The following is a description of a gene set: from publication Yevshin I, Sharipov R, Kolmykov S, Kondrakhin Y, Kolpakov F (PMID 30445619) Genes containing one or more binding sites for (TEAD2) in their promoter regions (TSS -1000,+100 bp) as identified by GTRD version 20.06 ChIP-seq harmonization. Human Gene Set: TEAD2_TARGET_GENES species: Homo sapiens, and this is the list of marker genes: ZRANB2-DT, SRP14-DT, TIGAR, PRDM10, SYDE2, PCNX4-DT, CARS2, DCP1B, SHOC2, H2AC6, RHBDD3, OGDH, GDF9, SEC14L1, LSR, TTLL7, PDCD6P1, TIMM22, RN7SL3, HUS1, POLG-DT, SYNJ2BP-COX16, GPAT3, CNBD2, PSMB9, ZNF397, MCM9, ATG12, NCAPD2, SRP14, SKA2, RABGAP1, DDX54, DEPDC4, RITA1, ZNF106, EIF4G2, POC5, UIMC1, SLC38A6, ITGAV, SMIM12, SNX8, TDRKH, LINC01342, PRMT1, SAMD4B, NIPAL3, VAV2, RPS4X, TDRKH-AS1 (NCBI Gene Id 109729141), OXR1-AS1, LATS2, MRPS33, MRPL42P1, TAF11, UQCR10, HOXA-AS3, SRSF7, STAT2, MIP, GPN3, AAAS, SCAF11, CCN1, LDLR, HSP90AB1, MFSD4B (major facilitator superfamily domain containing 4B), PRR5, RPL32, DST, SMARCA2 (NCBI Gene Id 95083), NOL7, TOLLIP-DT, HBP1, KIF3A, ENSG00000250230, ALDH4A1, TRIP6, POLR3B, GOT1-DT (GOT1 divergent transcript), RNU6-1, ATP5MG, PRDX2, WASF2, CFAP119, APOL2, MED19, RPS6KA1, SRSF1, RAB3GAP1, ATF7, MRPS10, ZMAT5, CENPO, LINC00339, SNHG20, LDAH, GCA, VPS33A, CPVL, RHOF, RAB21, PPP4R3B, TUBA1B, GIRGL, RALA, WDR36, TINF2, MIR3646, FAM133B, ATP8A1-DT, EHD1, SHLD3, PARPBP, RSRP1, TMEM183A, ATP1B3, ENSG00000246308, C2CD4A, C1orf105, MYL12A (myosin light chain 12A), CCDC90B, PIGB, ADO, ULK4, ZNF490, NEK4, YARS1, EIF5A, TLR3, DUS4L, POLR2K, RPRD2, GABARAPL1, PPRC1, TMEM68, ZNF691-DT, SNORA3A, PACSIN2, SNHG32, BECN1, MRPL27, METAP2, SUGT1-DT (NCBI Gene Id 116435302), GTF2A1-AS1, PSIP1, DHX30, CSNK1G3, SNX33, ERG28, CALM2, EEF1B2, POLG2, BTD (biotinidase), UFSP2, CRNKL1, FUCA1, CDC25C, CENPK, STRIP2, MRNIP, ATR, CBLL1, ENSG00000227218, ZBTB37, GPALPP1, PPM1D (protein phosphatase, Mg2+/Mn2+ dependent 1D), UTP3, AP3S2, GLRX, DLGAP4-AS1, HNRNPD, SMIM7, YAE1-DT, UBE2D3, COX15, HSD17B11 (NCBI Gene Id 51170), LINC01635, TK2, ASB3, RNF115, TAGAP-AS1, PRDM10-DT, EEF1AKMT3, TRIM23, TP53INP1, ZBTB8OS, LINC00471 (NCBI Gene Id 151477), HSPA5, PNO1, DAZAP2, SUGCT, ASAH1, PPM1L-DT, EIF3M (NCBI Gene Id 63319), CFDP1, LIPE, U2AF2, GPATCH2, SUCLG1, MIR200CHG, BCL7B, TPBG, ANKRD13A, PRMT5-AS1, ZNF691, TATDN3, PKNOX1, KIF18B, MOCS3, S100PBP, JADE2, ALDH1A2, CDON, POMK, CDCA3, FUS, H2AC7, ERCC5, YY1AP1, PPP2R5E, ABCF2, BOLA1, LINC00881, PBX3, ARMC8 (NCBI Gene Id 29067), BMERB1, MRPS24, PAFAH2, UBE4A, SHC1, KRT20, FAM227B, SPRY4, FAM156A, ASF1A, ITGA3, POLR1B, TAFA2, PEX5, ARHGAP26, SEPTIN9, PPA1, GAPDHP25, RPL26, PRR11, THADA (NCBI Gene Id 63892), KMT5A, H2BC12, FAF1, HRCT1, TUBA1B-AS1, RNF43, TSFM, MAPK14, INTS2, PKIB, FBXO33, CDCA7L, DNAAF8, TRIM40, MORN4, PPP1R21, LINC02026, LINC00921, SLC38A2-AS1, ABLIM1, TADA3, DCAF6, TYW1B, SMAD7, TIPIN, NAPA-AS1, LINC03060, NDUFS1, PRLR, RCHY1, RN7SK, DHPS, HSPBAP1, SNX27, VEZT, TSPAN13, RPL32P3, POLE3, TMEM69, MICOS10-NBL1, PBX3-DT, EIF3B, COMMD1, RPL6, MPDU1-AS1, CAPG, MIA2-AS1, PPM1B, NUP107, ZNF250, SNRNP27, GBF1, XRCC6, KDM4C, SNORA13, ZNRD2-DT, MXD3, EXD1, SAXO1, PLEKHA6, RARG, GTF3C2-AS2, RNFT1-DT, ABHD2 (NCBI Gene Id 654057), ZNF131 (NCBI Gene Id 7690), GPRC5A, TAF13, FABP3, H2BC5, RPL26L1 (NCBI Gene Id 51121), HDLBP, SMPDL3B, PRR5L, RAD50, MAT2A, BCL2L14, TMEM217, DPP3-DT, GATC, ARGLU1, SERF2, SRP54-AS1, NUP107-DT, NECTIN3, SLC30A6, TIRAP-AS1, ARL6IP6, DMAC2, CTR9, AFMID, WDR11-DT, SERTAD1, CHIT1, NR4A3, LUC7L2, RBBP4 (RB binding protein 4, chromatin remodeling factor), PDXDC2P-NPIPB14P, DTWD2, CLIC1, MIR4521, PSMD1, MACC1, MALAT1, TMEM260, RACK1, CCDC77, TBRG4, TEAD4, MORN5, RACGAP1, RBM14-RBM4, RPL4, CNOT9, KHDRBS3 (NCBI Gene Id 10656), LETMD1, PXN-AS1, TRMT12, PIGC, GNL1, GFM1, AFG1L, MRPL58, C9orf43, EIF3H, WDR6, POU2F1, SYS1-DBNDD2 (SYS1-DBNDD2 readthrough (NMD candidate)), AKR1D1, RAB29, TEAD1, RBM12, SZRD1, NOB1, P4HTM, FLNA, EXOSC8, EXOSC9, WWC2, PIP4K2B, SH3BP5L, MRPL49, HARS1, ITGA6, SPEF2, SEC11A, NGRN, KDSR, AFG2A, PTOV1, EIF2AK3, FAF2, TP53I3, FAM53C (family with sequence similarity 53 member C), SLC19A2, MADD, RPGRIP1L, CDIPT, TIMM21, MORN2, H2BC15, ANAPC5, LRRC41, DAXX, ASH2L, TOMM20, PJA2, MGRN1, LPAR1 (lysophosphatidic acid receptor 1), COMMD6, ATF7IP, EIF3F, RPL22, PRCC, GIT2, CDC40, H2BC4, POC1A, ATF4, CMC2, UBE2B, PCBP1-AS1, EPHA2, COQ10B, THAP7, C1orf74, TLCD1, LRFN4, ENSG00000259403, ZNF684 (zinc finger protein 684), RPS11, UBLCP1, PMS2, TAF1A-AS1, BPGM, MAP3K13, TOMM22, RN7SL832P, IFIH1, SLC16A13, RAB2B, FYCO1, NDUFS4, TATDN1, RNF207-AS1, CALCOCO1, NECAP1, MMADHC, KPNA4, POLR1G, MIA3, TNKS1BP1, SUCLA2, AKR1A1, CCT8, HAVCR2, RPIA (NCBI Gene Id 22934), SNORD84, SNHG29, ME3, RAB27A, MMP15, H4C4, ZBTB4, MCTP2, S100A11, USP8, PHRF1, LARP4, C11orf65, ENSG00000275765, RNVU1-30, PDXK, CFAP54, SAMD9L, ANKRD1, MIR3124, NDFIP2-AS1, TBC1D22B, DNAAF10, IFT52, POT1-AS1, ANAPC7, IPP, GIPC1, PHLDA1, VPS4B, EPHB3, PPP6R1, MYBBP1A, MEIS2, SUPT4H1, RPS17, PPP2CA, CARD8-AS1, RAB3D, ZNF302 (NCBI Gene Id 82167), USP37, JMY, GATA6-AS1, H2BC21, VTRNA1-2, H2AZ2, TMEM9B, MPLKIP, LEO1, SNHG11, GTPBP8 (NCBI Gene Id 29083), FBXO15, ABHD17C, POLR1HASP, NDFIP2, NUFIP1, MIR4638, QRICH1, INTS14, MTHFS, RTF1, RPL19, TSPAN4 (tetraspanin 4), RIBC1, TRIM41, ARMH3, CWC27, CDCA8, TARDBP, AP3B1, LMAN2, TTI1, PFDN4, GNG4, TAF1D, PNN, SGO1-AS1, RAP1GDS1, SMC3, UQCRC2, LINC02577, GGCX, LINC02453, CFAP298-TCP10L, GNB2, CDC6, OXR1, ATP5PF, TYW5, MRPL48, C22orf23, C17orf75, SMARCAL1, LINC02454, AP3S1, GABPB1-AS1, ST20, PPM1L, SDF2, SET, SMC1A, NOL8, TRIP10, SNRNP40 (small nuclear ribonucleoprotein U5 subunit 40), PRR13P5, GUK1, TAF1A, VPS72, UBXN6, UBAP2L (NCBI Gene Id 9898), MTO1, SDR39U1, TOMM22-DT, RNU2-63P, SRP54, MASTL, DPH3, GLYCTK, PPFIA3, DMXL2, CDK12, MIRLET7BHG, ZZEF1, GPBP1L1, CDIPTOSP, ORC3, RPS29P16, TMEM62, RNFT1, RNY4, INTS4, KNL1, MICAL3, TMEM200B, KIF18B-DT, PCYT1A, PRR15L, CD320, XPC, AKT1S1, SNRPA1-DT, UBE3C, SNHG15, CXCL16, TRIP4, APC, ZFAS1, MICOS10-DT, POLR2F, MRPL51, AGAP2-AS1, WDR62, ERLEC1 (NCBI Gene Id 27248), PIGV, PDXDC2P, PPP4R1L, PIF1, FIZ1, PSPH, PKIA, HNRNPLL, TRA2B, GRHL2-DT, SNRNP200, SGO1, PITPNM1, DNAJB5, ZFAND3, NUP35, MTARC2, XYLT2, ZNF524, CNOT8, TRIM2, TTC1, G3BP1 (G3BP stress granule assembly factor 1), SERP1, ATG101, MSL2, WRAP53, BTNL8, HIKESHI, LAMTOR5-AS1, CHASERR, DEDD, MAFK, UQCC6, CDK5RAP1, RRP9, VAMP8, RGS5, L3MBTL2, TMX2, MTMR14, ETFDH, MCRIP2, SEPTIN8 (NCBI Gene Id 23176), UQCRQ (ubiquinol-cytochrome c reductase complex III subunit VII), COMMD3, PTRHD1, EED, DDX5, SLC30A6-DT, NUTM1, SEC24C, MVK, ENO3 (NCBI Gene Id 2027), HINFP (histone H4 transcription factor), LINC02086, ARL1, ARID4B, GSK3A, FAM174B, MRPL34, SEC61G, TTC14, LIPE-AS1, MAPK7, HNRNPUL1, HOXA9, MVP, SMARCAL1-AS1, ZNF484, YME1L1, POLG, CHCHD3, ATAD2B, PSORS1C1, FNTB, DLGAP1-AS2, UQCRH, ARPC4-TTLL3, ANO6, MIGA1, GATAD1, TXNRD1, MUC1, ZFYVE16, PCK1, PFKFB3-AS1, ATPSCKMT, CFAP96, RNU1-117P, CCDC192, ATP6V1A, PRR3, PIGO-AS1, NBEAL1, NR4A2, ATP8A1, GTF2A1, SAE1, LBHD1, FER, PKP2, NECTIN3-AS1, PRPF38A, POLR3G, PCDH1, WDR54, PDXDC1, LSG1, RNU6-9, ARMH4, RPL27, ERC1, CEP57, VDAC2, PBRM1, RPS27A, PPP1R13L, SPATA20, BNIP2, RTN4, IER2, LINC02983, TM7SF3, CITED2, CLPX, ANGEL2, DDX28, MRPS17, METTL26, RPRD1B, ZSCAN22, MRPS16, FBXO45, ABCF1, SART3, DHX57, NSL1 (NSL1 component of MIS12 kinetochore complex), IMP3, UTP25, POLR3C, F2RL1 (NCBI Gene Id 7901), PPP1R12B (protein phosphatase 1 regulatory subunit 12B), GPSM3, BAZ2A, DNMBP, FUZ, MIR4766, AJUBA-DT, RAB28, MPPE1, HEXIM1, RPL26L1-AS1, TMEM219, ZCCHC17, MARCHF7, NUCB1, ICE1, VARS2, CALM3, HARS2, IARS1, STPG1, ENSG00000268460, SLC25A36, SLC7A6, FRMD4B, CKLF, ENSG00000260136, DUT-AS1, NELFA, SUPT7L, OSBP, C19orf53, PLOD3, DPP9, LINC01730, EIF1, POLR2A, METTL2B, SPRING1, CCNB2 (cyclin B2), ALG5, DDX19A (DEAD-box helicase 19A), DPM1, CD27-AS1, RNASEK-C17orf49, RELCH (NCBI Gene Id 57614), C4orf46, GABPB1, AFF1, ENSG00000233017, SIDT2, ERBB2, ZWILCH, CYP51A1, DNMT1, TMEM87A, CNOT4, MIR615, SLC38A4-AS1, DRG2, ATF7-NPFF, KCNQ2, CDH17, ACCS, GEMIN2, DNAJB5-DT, BMS1P4, SLC3A2, CENPP, EIF2A, LINC01275, UBXN2A, PPP3CB-AS1, UBXN7, CLDN4, ZNF180, B9D1, MSMO1, CUL2, SMIM31, ACTR1A, SMIM2-AS1, MINDY1, CHD2, ZNF622, PAIP2, STOML2, UTP18, PPFIBP1, PSMA3-AS1, CDH24, PANK1, VPS41, CLHC1, SLC24A1, PIGN, CLDN12, IFRD1, ZDHHC7, AIRIM, HSDL2, MIR3143, RHOBTB3, FNBP1P1, SF3A3, PPARD, ZSCAN26, POLR2J3, H2AC12, TGFBR2, C5orf24, ST20-MTHFS, H2AZ2-DT, AP1M2, TEC, HNRNPD-DT, NOL6, ERCC6L2-AS1, SNORD12C, MRPL46, DIAPH1, OXNAD1, FAM227A, TMEM205, HSPA1B, ZNF747-DT, DTWD1, SUGT1, UROS, ENSG00000232995, PSMC2, H4C8, ZSCAN25, EID1, KRT8 (keratin 8), NDUFA4, RIMOC1, SLC4A1AP, ZFP62, SEM1, SCNM1, MPZL2, H3-3B, SYS1, DBR1, NDUFC2-KCTD14, HACD1, ISY1, CEP95, RPS29, ATF5, REG4, ZDHHC5, CYRIB, PRPF40A, NGDN, SDE2, DHCR24-DT, CSPP1, ALOXE3, NDUFB9, SEC61G-DT, ZNF384, CFAP298, MED7, GAU1, CDKL3, ZNF391, MBTD1, STOML1, UCHL3, R3HCC1, ANKS3, RILP, LSM8, MATR3, RFC2, PPAT, SHMT2, LRRC51, PSMB4, WDR53, DPM2, SNORD59A, LGR5, TMEM38A, ZNF747, MED8, UFD1, NR6A1 (nuclear receptor subfamily 6 group A member 1), DRAIC, BZW1, CNOT10, LINC00513, FAAP20, LINC02889, LRPPRC, SETDB1, BRD2, IL4I1, FKBP2, LAMTOR2 (NCBI Gene Id 94954), EHF, TAMM41, PDHB, GSTA4, CCDC12, CCDC90B-AS1, KDM3A, BRAF, CIRBP-AS1, MGAT5, USP15, RPL21P19, OPA3, PHKG2, SEPTIN7, CLIP1, INKA1, UBN2, SLFN12, TK1, LRP10, UQCRB, PRSS22, DDX19A-DT, CCDC159, CLRN3, TM9SF2, TOR4A, ETS2-AS1, ZRANB2, RIOK2, GGPS1, IP6K1, PNPT1, IL1R2, NARS1, EIF4A1, HSPA8, MTFR1, FLCN, KIF11 (kinesin family member 11), H2AC20, H2BC7, TRMT61B, POLR1H, FEM1A, RNU5E-6P, GOT1, NPM1 (nucleophosmin 1), GAS5, RPL18A, C1orf174, GAPDH, PIGBOS1, CDKN2C, TMEM97, ZNF121, PSME3IP1, S100A6, ITM2B, ZNF33A, RAD54B, BAZ1B, MED15, VPS13A-AS1, MYO1E, SELENOK (NCBI Gene Id 58515), GRIPAP1, ASB7, DAP3, DENND4A, MYO9B, ERGIC3, PTCD2, EEF1A1, ATG5, SNX13, DPP3, CFAP61, STK35, PTGES3, RBCK1, ZFAND3-DT, STK11IP, LINC02960, DHCR24, ZNF263, LSM11, MANCR, MIR4258, AK2, GPR19, RNU6ATAC, STRIP1, TIMM13, SH2D6, CSNK2A1, RN7SL2, RNU6-92P, GON4L, ENSG00000233230, C1GALT1, CDK16, CENPN, POLR2M, NDUFC1 (NADH:ubiquinone oxidoreductase subunit C1), CYC1, CNOT1, NUP37, ZNF212, RRM2, CNPY2, SEPTIN6, RSU1, GLIPR1L1, CCND2, ECD, BSCL2, CTDSP1, S100A16, PSME3, ATP5F1B, PARK7, TAF10, RBM14, TRAPPC13, CPNE1, SUPV3L1, SRPK1, SERPINB5, MIA2, SERINC1, DGKG, GARNL3, MRPS31P5, DDX50 (DExD-box helicase 50), GTF2H4, LINC01089, C10orf143, ANKS6, RNF34, RPLP0, GET3, ZC2HC1C, COG3, PARP3 (poly(ADP-ribose) polymerase family member 3), DDX18, BRAP, EXOSC4, KPTN, BAHCC1, NEMF, SREK1IP1, SASH1, UBE2D3-AS1, PIGO (NCBI Gene Id 84720), DOC2A, NUP205, RPS6KB1, HPS5, LAMTOR5, SCAND1, ENSG00000261335, ZNRD2, GCN1, PCBP1, LINC02168, PRR15, GNL3, UQCRB-AS1, CIRBP, LRCH3, LINS1, MPC2, RNA5SP21, CDK5RAP3, EEF1G, CCDC15, DNAJC28, TBC1D2, TBC1D17, TGIF2, XPO1, TDP2, TOE1, FTO, TRMO, UTP23, COX5A, COPS5, STAT3, TCP11L2, CEP63, MIR4512, WASF1, LSM10, VPS26A, PPP1R14B, SCAT2, TP53TG1 (NCBI Gene Id 11257), DDX39B-AS1, UNC45A, PLXDC1, SNX1, SEC31A, CPNE2 (NCBI Gene Id 8903), GEMIN6, ARID4A, BRAT1, WDR82, FAM76B, OXCT1-AS1, HDAC2 (histone deacetylase 2), CEP128, PYGB, FRG1HP, IBTK, PPIP5K2, ASB1, ATP1A1-AS1, RSPH3, MFSD4B-DT, HDAC1, GOLGA5, RNFT2, LZTS2, SNORD49B, ATG7, RPS5, MED4, EWSR1, DDX17, CREB3L2, FANCI, VPS45, SPATA17, PCBP2, TBC1D10A, MTIF2, SELENOH, CCDC86, SON, ZNF335, SDHC, CATSPERD, HYAL2, PGGT1B, LINC00511, SEPTIN2, SCYL2, NUS1, ADCY6, FAM98A, MNS1, DUS2, RPL13A, HOXA-AS2, TPR, NAPEPLD (NCBI Gene Id 222236), ABCA15P, ENTPD4-DT, CPEB3, ENSG00000257184, PDIA4, PCLAF, PFKFB3 (NCBI Gene Id 5209), RHBDF1, RGS20, ZNF219, LIMA1, BRCA2, CCT5 (chaperonin containing TCP1 subunit 5), MRPS11, HNRNPH3, RPL21P117, EMC6, STX10, UBXN1, PTGER4, SHF, SCARNA16, WDR11, NANS, REXO4, ACYP1, DDIAS, ZNF770, PPIA, EHMT2, DDX46, CSRNP2, FUT10, DDX39B, RPL22L1, NAT10, IWS1, RAD52, ANAPC13, UQCC3, MED16, MRPL24, NKTR, LRR1, FAM149B1, RAB11A, DHRS4-AS1, DMKN, GTF2A2, MAOA, ARHGAP32, MIR4757, SEPTIN7-DT, ENSG00000232876, C2orf49, LAPTM4A, DOHH, HACL1, PSMB8, DBP, HAUS8, GTF2H1, ATN1, CXCL3, DPP8 (dipeptidyl peptidase 8), PANK3, EIF3D, RBM23, MAIP1, HDAC2-AS2, COX6A1, NCOR2, ZNF815P (NCBI Gene Id 402455), CPEB4, PML, AP1G2 (adaptor related protein complex 1 subunit gamma 2), NR1H2, GTF3C2, ZNF609, NUMA1, BMS1P4-AGAP5, ZNF48, ZDHHC2, IFT172, PIK3R3, CFL1P1, MYL12-AS1, UBA1, MPDU1, ERCC6L2, TRAF3IP2, RNF125, SS18, CHD8, KLHDC10, RNU4ATAC, CDC45, NAA50, NUF2, RARS2, NDUFC2, MIR4754, FSIP1, RNF40, DYNC1I2, ODAD3 (NCBI Gene Id 115948), PDCD6IP, P4HA1, CBY1, H3C1, MST1P2, ZBTB2, GPR108, FAM110A (NCBI Gene Id 83541), ZNF584-DT, ZNFX1, PIDD1, RPL27A, PAICS (phosphoribosylaminoimidazole carboxylase and phosphoribosylaminoimidazolesuccinocarboxamide synthase), PRKCSH, NDUFB7 (NCBI Gene Id 4713), KAZALD1, MYL12B, SZT2, ASAH1-AS1, RPLP2, RBM17, TIMM17B, PA2G4, TUBD1, CROT, FAM43A, SRI, LINC02252, ZSCAN31, ISCU, UMPS, AIMP2, RNF207, MUTYH, LINC03064, THAP7-AS1, ANKMY2, RPL24, CEACAM19, BCAR3-AS1, KRR1, C5orf15, MEX3C, IDE, ZNF546, PDE12, TMEM9B-AS1, GAPDH-DT, UACA, ZAR1L, SOCS5, HACD2, CHTOP, ZNHIT1, RBM7, PRRC2C, RPAP1, PQBP1, BBIP1, KHSRP, FNDC3A, OPLAH, EIF2B2, FOXRED2, DYNC2I2, RPL31, PRKCI, GIN1, MRPS27, MIDEAS, HBS1L, NUP62 (NCBI Gene Id 51551), EPB41L4A-AS1, LYSMD1, RAB18, CREBL2, ZNF346, CACYBP, THAP6, PHLDA1-DT, NAA15, MRNIP-DT, CCT6A, ISCA1, LONP1, DDX21, ACP3, BZW2, SRCAP, RNASEK, CCDC54-AS1, EME1, BCCIP, SDF2L1, ZBTB47-AS1, STYK1, IGFL2-AS1, PREP, KITLG, CLASP1, ZNF184, PPWD1, RALBP1, DUT, ZCCHC4, SSR3, SUN1, SINHCAF, ISY1-RAB43, GALNT7, SIRT4, EIF2AK3-DT, TRMT5, GPR39 (G protein-coupled receptor 39), GLUD1P3, PRCP, PKP4, MICOS10, NOCT, ITSN1, CROCCP2, VDR, LAPTM4A-DT, SLC38A2, TOX4, CD164, BCL6, STAT6, BRWD1, BCAS3, HDGF, FAU, DMXL1, POU2F1-DT (POU2F1 divergent transcript), TRIAP1, RPS14, TMA16, SIL1, LRP6, CXXC1, ZSCAN9, SNAP23, CCDC148, LINC00938, AKAP1, RNVU1-15, WDR70, YWHAE, RPS3A, SNORD48, ASB8, WSB2, TTC14-DT, NIFK-AS1, LINC01732, AHR, ACACA, HECW2-AS1, BORCS8, TAPBPL, MYLK-AS1, LIN54, POU6F2, GNS (NCBI Gene Id 2799), AJUBA, YAE1, SHC4, TOLLIP, FRAT1, BHLHE41, ARPC4, CKS1B, PCNX4, MYL6, ENTPD4, GPNMB, IMMP1LP1, GTSE1, ENSG00000239137, CHP1, RPA2, GGCT, FAM81A, ACAD10, DNAAF3, ATG16L2, ESR2, RBBP8NL, IQGAP2 (NCBI Gene Id 10788), LINC02980 (NCBI Gene Id 124906555), GART, TBPL1, RGS9, MEIS1 (Meis homeobox 1), VDAC3, ASTE1, MIOS, MALSU1, GTSE1-DT, LEPROTL1, LINC00944, USP53, SNORD95, ENSA, SRSF10, WDSUB1, ODR4